The following is a description of a gene set: studied in species Homo sapiens Human Gene Set: GOMF_MHC_CLASS_IB_PROTEIN_BINDING Binding to a major histocompatibility complex class Ib molecules., and this is the list of marker genes: KLRD1, KIR2DS4 (killer cell immunoglobulin like receptor, two Ig domains and short cytoplasmic tail 4), KIR3DL2, LILRB1, TAP2, CYRIB, LILRB2, TAP1